The following is a description of a gene set: studied in species Mus musculus electronically inferred by orthology from the curated human pathway This event has been computationally inferred from an event that has been demonstrated in another species.<p>The inference is based on the homology mapping from PANTHER. Briefly, reactions for which all involved PhysicalEntities (in input, output and catalyst) have a mapped orthologue/paralogue (for complexes at least 75% of components must have a mapping) are inferred to the other species. Reactome Pathway: Hemostasis, and this is the list of marker genes: H3c11, Itih3, Rab27b, Racgap1, Atp1b2, H3c4, Jaml, Anxa2, Dgka, Brpf3, Pik3r5, P2rx7, Kif26a, Yes1, Chid1, Gata4, Kif2c, Maged2, Ptpn1, Ppp2r5d, Esam, Apoa1, Dgki, Calm1, Vegfc, Col1a2, Tor4a, Mafk, Maff, Hrg, Sparc, Tln1, Plaur, Gngt2, Csk, Fyn, Ak3, Orm2, Gng7, Tex264, Smpd1, Atp2a1, H3c15, Plau, Dock11, Pde10a, Rac2, Gnb5, Tubb6, Kifap3, Tuba4a, Itih4, Crk, Plcg2, Gng5, Rad51c, Proz, Pcdh7, Mfn2, Alb, Mapk14, Abcc4, Sh2b3, Psap, Tubb4a, Rasgrp1, Ppp2r5b, Mertk, Adra2c, Dock5, Syk, Slc7a6, Igll1, Gnai1, Adra2b, Ehd3, Gna14, Cfd (complement factor D), Cdc37l1, P2rx2, Lcp2, Fgg, Pdpk1, Tuba1a, H3c7, Serpind1, Ppia, Mif, H3c6, Prkar1b, Gnat3 (G protein subunit alpha transducin 3), Sdc3, H3c10, Angpt2, F2rl3, P2rx6, Zfpm1 (NCBI Gene Id 22761), Slc16a3, Atp2b4, Tuba1b (tubulin, alpha 1B), Trpc7, Stxbp3, Ehd2, Prkaca (protein kinase, cAMP dependent, catalytic, alpha), Apob, Lgals3bp, Slc3a2, Sdc1, Kng2, H3f3a, Tuba3b, Pde5a, Itga2b, Rbsn, Klc3, Gng8, Gas6, Fgr, Gng10, Gtpbp2 (NCBI Gene Id 56055), Tuba8, Itgb2, Gp9, Prkca, Gng11, F12, Tmsb4x, H3c3, Serping1, Pdpn, Sele, Gna13, Atp1b3, Pf4, Gata2, Gng3, Ahsg, Proc, F9, Kif21a, Mapk3, Trf, Gnb2, Prtn3, Bcar1, Dock8, Spp2, Dock2, Kif2b, F8, Tgfb1, Dagla (diacylglycerol lipase, alpha), Itgax, F10, Ptgir, Klc4, Ano5, F7, Aldoa, Fam3c, H3c13, Kif5b, Tubal3, Cd36, Nhlrc2 (NHL repeat containing 2), F2, Daglb, Kif12 (NCBI Gene Id 16552), Cd9, Klkb1, Atp2a3, Lat, Serpina10, Plg, Glg1, Vegfa, F13a1, Gna12, Selp, Shc1, Cdc42, H3c2, Lamp2, Prkacb, Pdgfb, Tmx3, Gp1ba, Kif18b, Pde2a, Trem1, Pik3r2, Ptk2, Gp1bb, Trpc6, Gpc3, Gng4, Atp2b3, P2ry1, Prkar2b, Gata3, Apbb1ip, Ceacam1 (NCBI Gene Id 26365), H3c8 (NCBI Gene Id 97908), Kif3c, Fcamr, Slc7a10, Ly6g6f, Lhfpl2, Bsg, Serpinf2, Lrp8, Vegfd, Serpinb2, Mag, Slc7a7 (NCBI Gene Id 20540), Slc7a9, Islr, Timp1 (tissue inhibitor of metalloproteinase 1), Aplp2, Ehd1, Cd74, Kif9, Itga3, Ppil2, Pdgfa, Gata6, Hras, Mpig6b, Serpina5, Nos2, Prkcg, Kif20a, Tubb2b, Lck, Prkch, F13b, Tubb4b, Pik3cb, Kif27, Rarres2, Serpine2, Atp1b1, Angpt4, Vav1, Adamts13, Nfe2, Dgkh, Adra2a, Gnb3, Ppp2r1b, Gata1, Hgf, Tbxa2r, Itpk1, Pde1b, Grb2, Stx4a, Sytl4, Spn, Itga4, Pcyox1l, Slc16a8, Pros1, Tuba1c, Scg3, Rad51b, Dok2, Mmrn1, Orm1, Kif1b, Gpc2, Cav1, Itga5, A2m, Arrb2, Cenpe, P2rx5, Ctsw, Vegfb, Pde9a (NCBI Gene Id 18585), Epcam, Igf2, Srgn, Cd109, Slc7a8, Serpinb8, H3c1, Apoh, Ppp2r5a, Gngt1, Rhob, Kdm1a, Itgal, Dgkb, Cd177, Ptpn6, Atp2b1